Given this list of marker genes HBQ1, HBG1, PRDX5, PRDX1, PRDX4, HBD, PXDNL, HBG2, HBE1, SNCA, LPO, GPX3, MT3, PRDX3, NNT, DUOX2, HP, MPO, PRDX2, DUOX1, HBB, PRDX6, HBZ, PXDN, HBM, EPX, HBA1, GPX1, HBA2, APOA4, CAT, TPO, here is a description of the gene set: species: Homo sapiens The chemical reactions and pathways resulting in the breakdown of hydrogen peroxide (H2O2). Human Gene Set: GOBP_HYDROGEN_PEROXIDE_CATABOLIC_PROCESS